Given this list of marker genes Jun, Zfp36l2, Klf6, Hspa1b, Emb, Klf2, Tsc22d3, Hspa1a, Fos, Junb, Dusp1, Ier5, Uba52, Jund, here is a description of the gene set: Cytokines mediate cell-cell communication in the immune system and represent important therapeutic targets. A myriad of studies have highlighted their central role in immune function, yet we lack a global view of the cellular responses of each immune cell type to each cytokine. To address this gap, the authors created the Immune Dictionary, a compendium of single-cell transcriptomic profiles of more than 17 immune cell types in response to each of 86 cytokines (>1,400 cytokine-cell type combinations) in mouse lymph nodes in vivo. A cytokine-centric view of the dictionary revealed that most cytokines induce highly cell-type-specific responses. For example, the inflammatory cytokine interleukin-1β induces distinct gene programmes in almost every cell type. A cell-type-centric view of the dictionary identified more than 66 cytokine-driven cellular polarization states across immune cell types, including previously uncharacterized states such as an interleukin-18-induced polyfunctional natural killer cell state. Genes negatively differentially expressed in cell type: NK cell upon treatment with cytokine: BAFF in mouse lymph nodes in vivo. studied in species Mus musculus Mouse Gene Set: CUI_NK_CELL_BAFF_RESPONSE_DN from publication Cui A, Huang T, Li S, Ma A, Pérez JL, Sander C, Keskin DB, Wu CJ, Fraenkel E, Hacohen N (PMID 38057668)